Given this list of marker genes Mpped1, Wnt3, Dcun1d2, Nek11, Phc2, Stom, Mycl, Tanc2, Rbck1, Rhov, Glt8d1, Arrdc3, Smchd1, Nr5a2, Eif5a2, Phb1, Ecel1, Chrna1, Morn4, Alx4, Olfm5, Sfxn5, Paqr7, Zdhhc24, Poldip2, Tcf7l1, Rbfox2, Tom1l2, Ift88, Slc7a6 (NCBI Gene Id 330836), Fam3c, Rer1, Ccdc134, Nrg4, Slc7a1, Tshz1, Slc37a2, Hmgxb4, Rab43, Map2k3, Zcchc14, Hoxd3, Mfsd3, Cdc25b, Slc6a2, Chd3, Naa60, Zc3h10 (zinc finger CCCH type containing 10), Cnn2, Tppp, 6430571L13Rik, Dlg4, Nfkbie, Lix1l, Zfr2, Ppp2r2c, Olfml1, Oaz2, Syt14, Mylk2, Als2cl, Ntsr1, Gm5878, Spns2, Rab4b, Jph3, Synpo, Crtc1, Mrps25, Septin5, Tceanc, Tmem235, Sh3pxd2a, Grhl2, Preb, Kcnd3, Enho, Psen1, Nat8l, Ppp1r27, Sdc3, Ephb2, Gnb1, Zbtb4, Eda, Icam1, Sirt3, Eaf1, Kctd14, Slc12a4, Zfp13, Agap1, Arf4, Plxna4, Slc2a1, Zwint, Osgep, Rab29, Ppfia3, Smg7, Kdm4b, Dab2ip, Efnb1, Syn1 (NCBI Gene Id 20964), Brms1 (breast cancer metastasis-suppressor 1), Gigyf2, Itpr2, Dexi, Ttyh3, Mapre2, Pcnx3, Emilin2, Bcl2l13, Cpne4, Igll1 (NCBI Gene Id 16136, immunoglobulin lambda-like polypeptide 1), Edc3, Pogk, Nudt13, Ehmt2, Pdgfrb (NCBI Gene Id 18596), Scara5, Chd5, Pus7, Dag1, here is a description of the gene set: species: Mus musculus Genes predicted to be targets of miRBase v22 microRNA mmu_miR_12181_3p in miRDB v6.0 with MirTarget v4 prediction scores > 80 (high confidence targets). Mouse Gene Set: MIR_12181_3P from publication Chen Y, Wang X (PMID 31504780)